Given this list of marker genes Hjurp, Fzr1, Lcmt1, Plk1, Xpo1, Cdc25c, Wee1, Ppme1, Cdk1, Ccnb1, Ccnh, Ppp2r1b, Obi1, Ccna1, Ticrr, Ppp2r2a, Bora, here is a description of the gene set: Reactome Pathway: Cyclin A/B1/B2 associated events during G2/M transition part of: G2/M Transition electronically inferred by orthology from the curated human pathway studied in species Mus musculus This event has been computationally inferred from an event that has been demonstrated in another species.<p>The inference is based on the homology mapping from PANTHER. Briefly, reactions for which all involved PhysicalEntities (in input, output and catalyst) have a mapped orthologue/paralogue (for complexes at least 75% of components must have a mapping) are inferred to the other species.